The following is a description of a gene set: Human infertility and recurrent pregnancy loss caused by implantation defects are poorly understood. Hoxa-10-deficient female mice have severe infertility and recurrent pregnancy loss due to defective uterine implantation. Gene expression profiling experiments reveal that Hoxa-10 is an important regulator of two critical events in implantation: stromal cell proliferation and local immunosuppression. At the time of implantation, Hoxa-10 mediates the progesterone-stimulated proliferation of uterine stromal cells. Hoxa-10 mutants express a stromal cell proliferation defect that is accompanied by quantitative or spatial alterations in the expression of two cyclin-dependent kinase inhibitor genes, p57 and p15. Hoxa-10 deficiency also leads to a severe local immunological disturbance, characterized by a polyclonal proliferation of T cells, that occurs in place of the normal progesterone-mediated immunosuppression in the periimplantation uterus. Mouse Gene Set: YAO_TEMPORAL_RESPONSE_TO_PROGESTERONE_CLUSTER_8 from publication Yao MW, Lim H, Schust DJ, Choe SE, Farago A, Ding Y, Michaud S, Church GM, Maas RL (PMID 12554760) Genes co-regulated in uterus during a time course response to progesterone: SOM cluster 8. studied in species Mus musculus, and this is the list of marker genes: Pdk3, Tgfbr3, Hsph1, Lmo7, Hopx, Gm5796, Slco3a1, Usp14, Id1, Ctps1, Bmp2k, Mthfd2, Srsf1, Hk2, Tfrc, Gata2, Fzd1, Bcat1, Caprin2, Mat2a, P4ha2, Myc, Ccng1, Ptgs1, Atp5f1c, Sgk1, Alpl, Wnt11, Hoxa11, Pnkd, Pdzk1ip1, Ckmt1, Nfil3, Dnajc3, Plet1, Stx18, Zbtb16, Rhob, Cyp26a1, Pip5k1b, Ggct, Slc2a3, Noct, Ihh, Wdr43, Fst, Myd88, Ank, Fkbp5, Etnk1, Ptk2b